The following is a description of a gene set: Reactome Pathway: SUMOylation of DNA damage response and repair proteins part of: SUMO E3 ligases SUMOylate target proteins studied in species Homo sapiens Several factors that participate in DNA damage response and repair are SUMOylated. SUMOylation can alter enzymatic activity and protein stability or it can serve to recruit additional factors. For example, SUMOylation of Thymine DNA glycosylase (TDG) causes TDG to lose affinity for its product, an abasic site opposite a G residue, and thus increases turnover of the enzyme. During repair of double-strand breaks SUMO1, SUMO2, SUMO3, and the SUMO E3 ligases PIAS1 and PIAS4 accumulate at double-strand breaks where BRCA1, HERC1, RNF168, MDC1, and TP53BP1 are SUMOylated. SUMOylation of BRCA1 may increase its ubiquitin ligase activity while SUMOylation of MDC1 and HERC2 appears to play a role in recruitment of proteins such as RNF4 and RNF8 to double strand breaks. Similarly SUMOylation of RPA1 (RPA70) recruits RAD51 in the homologous recombination pathway., and this is the list of marker genes: NUP43, SMC1A, SEC13, RPA1, EID3, NUP188, SCMH1, SMC6, NUP214, RAD52, HERC2, SUMO2, NSMCE1, BLM, PIAS1, PIAS4, RAD21, PHC1, CDKN2A, TDG, NUP155, CBX2, AAAS, NUP160, NUP107, WRN, RING1, NSMCE4A, POM121, CBX4, SMC3, POM121C, NDC1, NUP62, PHC3, NUP153, NUP93, NUP35, PCGF2, SEH1L, SMC5, PARP1, XRCC4, NUP37 (NCBI Gene Id 79023), PHC2, NUP85, STAG2 (STAG2 cohesin complex component), NSMCE3, XPC (XPC complex subunit, DNA damage recognition and repair factor), NUP205 (NCBI Gene Id 23165), UBE2I, NUP133, SP100, SUMO3, PIAS2, SUMO1 (small ubiquitin like modifier 1), HDAC7, NUP98, NUP88, RNF168, STAG1, NUP54, BMI1, CETN2, RANBP2, CBX8, RNF2, NUP42, RAE1, PML, TPR, NUP50, NSMCE2, MDC1, NUP58, NUP210, BRCA1